The following is a description of a gene set: Mouse Gene Set: GOBP_REGULATION_OF_CELL_FATE_COMMITMENT studied in species Mus musculus Any process that modulates the frequency, rate or extent of cell fate commitment. Cell fate commitment is the commitment of cells to specific cell fates and their capacity to differentiate into particular kinds of cells. Positional information is established through protein signals that emanate from a localized source within a cell (the initial one-cell zygote) or within a developmental field., and this is the list of marker genes: Mbd3, Cd69, Sostdc1, Mta3 (NCBI Gene Id 68548), Sfrp2, Hdac1, Fzd7, Lmo4, Bmpr1a, Opa1, Hdac2, Lgals1, Rbbp4, Spdef, Pax6, Tbx21, Brd4, Hes1, Gfi1, Bmp4, Gatad2b, Mta2, Gatad2a, Il23a, Mta1, Chd4, Ep300, Casz1 (castor zinc finger 1), Nanog, Mesp1, Dkk1, Pax7, Brd2, Wnt3a, Fgfr1, Fgf2, Gdf3, Tnfsf18, Zfp157, Rbbp7, Nkx6-2, Glis1, Loxl3, Sox17, Esrp1